Given this list of marker genes Ocel1, Pp2d1, Phf6, Glis3, Fnbp1l, Vps35, Rnf114, Egr3, Col4a6, Mcpt4, Thap2, Abi2 (abl interactor 2), Ppm1a, Chmp6, Cngb1, Ttll4, Nrm, Garre1, Ccnyl1, Tmem68, Nexmif, Vsig4, Tarbp1, Efs, Adam28, Slc9a1, Car7, Grin3a, Mlph, Mcpt1, Sap130, Zfp217, Gatad2a, Nampt, Gprc5c, Pirt, Dgkh, here is a description of the gene set: from publication Chen Y, Wang X (PMID 31504780) Mouse Gene Set: MIR_1902 Genes predicted to be targets of miRBase v22 microRNA mmu_miR_1902 in miRDB v6.0 with MirTarget v4 prediction scores > 80 (high confidence targets). studied in species Mus musculus